The following is a description of a gene set: Omega-shaped (as in the Greek capital letter) intracellular membrane-bounded organelle enriched in phosphatidylinositol 3-phosphate and dynamically connected to the endoplasmic reticulum. Omegasomes are the first step of the formation of autophagosomes via the phagophore assembly sites. species: Mus musculus Mouse Gene Set: GOCC_OMEGASOME, and this is the list of marker genes: Ulk1 (unc-51 like kinase 1), Emc6, Trim30d, Trim30c, Zfyve1, Trim30a, Trim12a, Atg14, Trim12c, Trim5, Trim30b